Given this list of marker genes RAD21, NCBP2, POLR2I, ZZZ3, ILF2, SPCS2, POP5, SHMT1, G3BP1 (G3BP stress granule assembly factor 1), PWP1, NUP188, METAP1, SET, GPAA1, RBMX, HSPA8, POLE3, ICE1, SART3, MSH2, EIF2B4, PRMT1, ACTL6A, HNRNPA2B1, RPA1 (replication protein A1), MTA1, RAC1, SP3 (Sp3 transcription factor), COPS5, HNRNPAB, SNRNP200, PRPSAP1, SDHA, IK, TMEM106C, USP1, CLNS1A, DDX39A, AIMP2, SYNCRIP, SOD1, HNRNPU, COIL, GTF2H1, LYPLA1, SUMO1, HAT1, RFC4, PARG (NCBI Gene Id 95267), CFDP1, PSMB6, UNG, DEK, CYB5B, KARS1, PSMD7, RAD23B, HDAC2, FBXW11, YWHAQ (NCBI Gene Id 10971), KHDRBS1, here is a description of the gene set: Neighborhood of RPA1 replication protein A1, 70kDa in the MORF expression compendium studied in species Homo sapiens Human Gene Set: MORF_RPA1 Neighborhood of RPA1